Given this list of marker genes SLC29A4, SLC22A1, LRP5, SLC22A3, LRP6, SLC17A3, SLC22A2, ABCG1, SLC7A8 (solute carrier family 7 member 8), here is a description of the gene set: Enables the transfer of a toxin from one side of a membrane to the other. A toxin is a poisonous compound (typically a protein) that is produced by cells or organisms and that can cause disease when introduced into the body or tissues of an organism. species: Homo sapiens Human Gene Set: GOMF_TOXIN_TRANSMEMBRANE_TRANSPORTER_ACTIVITY